Given this list of marker genes IFNG, TSC2, PTEN, SLC25A24, TSC1, here is a description of the gene set: Human Gene Set: HP_SHAGREEN_PATCH Shagreen patch A plaque representing a connective-tissue nevus. Connective tissue naevi are uncommon skin lesions that occur when the deeper layers of the skin do not develop correctly or the components of these layers occur in the wrong proportion. Shagreen patches are oval-shaped and nevoid, skin-colored or occasionally pigmented, smooth or crinkled. The word shagreen refers to a type of roughened untanned leather. species: Homo sapiens